The following is a description of a gene set: studied in species Homo sapiens Coronaviruses are a group of enveloped viruses with single‑stranded, positive‑sense RNA genomes. Each of the steps of viral replication - attachment and entry, translation of viral replicase, genome transcription and replication, translation of structural proteins, and virion assembly and release - involves host factors. These interactions can cause alterations in cellular structure and physiology, and activate host stress responses, autophagy, cell death, and processes of innate immunity (Fung TS & Liu DX 2019). Reactome Pathway: SARS-CoV-2-host interactions part of: SARS-CoV-2 Infection, and this is the list of marker genes: HSP90AB1, ISG15, NUP58, HLA-G, NUP88, VPS33A, 8, UBA52, CHUK, RIGI, IRF7, NOD2, YWHAE, RPS21, RPS19, GEMIN6, RPS4Y1, IFNA2, PATJ, MAP3K7, SEC24D, B2M, CNBP, rep, IFNB1, NUP214, NUP85, NOD1, IFNA21, YWHAZ, TOMM70, TRAF6, HLA-F, IFNA10, IFNAR1, SFTPD, LARP1, TLR8, NUP43, IKBKB, 7SL RNA (ENSG00000222619), TLR2, TKFC, IFNA5, TRIM25, VPS18, POM121C, RPS6, UBC, HLA-C, RPS23, RPS15A, UVRAG, HLA-E, GEMIN2, JAK1, VPS41, NUP35, HLA-B, SEC24C, SNRPB, S, SARS coronavirus, complete genome, PIK3R4, IFNAR2, RPS7, GEMIN8, STING1, GEMIN4, RANBP2, IRAK2, IL17A, SEC23A, UBE2N, IL17F, PTPN11, PIK3C3, GJA1, CAV1, NUP153, SAR1B, NUP62, RPS5, NUP98, GEMIN7, VPS16, YWHAG, RPS4X, IFNA14, NUP54, MBL2, VPS45, RPS11, NUP160, MASP1, 3a, pp1a, IFNA8, CREBBP, GEMIN5, SNRPF, M, RPS14, TJP1, RPS24, PDPK1, TLR1, IFIH1, VPS33B, RPS18, RPS4Y2, RPS12, RPS8, IKBKG, PALS1, NUP93, MAP1LC3B, AKT1, RAE1, RPS16, RPSA, FAU, TYK2, VPS39, 7SL RNA (ENSG00000222639), UBE2V1, RPS25, IRAK1, RNF135, IFNA16, NUP50, IL17RA, PTPN6, RPS17 (NCBI Gene Id 6218), SNRPD3, YWHAB, RIPK2, N, RPS26, DDX20, NDC1, AAAS, E, SNRPE, SIKE1, RPS10, 7a, IFNA6, NUP210, SEC24B, RPS27, RPS20, RPS2, NLRP3, RPS27L, UBB, VPS11, RPS9, RPS3, NLRP12, STAT1, IFNA17, G3BP1, SEC24A, RPS28, TUFM, SNRPG, HLA-H, RPS15, TRAF3, 9b, HLA-A, BECN1, YWHAQ, ATG14, IFNA1, NUP188, KPNA2, IFNA7, AKT3, NUP133, SEH1L, SMN1, 6, IRF3, TAB2, TAB3, NUP37, TPR, POM121, NUP155, MASP2, G3BP2, YWHAH, RPS29, RPS13, NUP107, MAVS, TRIM4, SNRPD2, IFNA4, TBK1, IL17RC, TLR7, TAB1, CRB3, HSP90AA1, AKT2, STAT2, NUP42, IKBKE, SNRPD1, RPS27A, 18S rRNA, SEC13, NUP205, RPS3A, SFN